Given this list of marker genes Mmp2, Ecm1, Atp1a1, Smarca1, Dusp16, Lpl, Arl4a, Mapk8, Runx1, Notch4, S100a6, Extl3, Htra1, Col7a1, Fabp3, Galnt3, Tns1, Cdkn2b, Tle3, Fzd6, Dnm2, Picalm, Cdc42ep5, Gfra1, Cald1, Tagln, Basp1, Foxp1, Jag1 (NCBI Gene Id 170642), Pcolce, Capg, Cyc1, Cnn3, Lipg, Krt18, Tgif1, G0s2, Ptpn14, Acaa2, Rad23a, Ccn1, Egr2, Net1, Galnt2, Ets2, Acta2, Gusb, Tsc22d1, Qki, Tjp2, Fabp5, Crim1, Plat, Ogfr, Ak2, Bpgm, Spin1, Sirpa, Chd4, Rpl27a, Srsf2, Hdlbp, Mfge8, Ceacam1, Egln1, Ehd1, Car8, Epas1, Cap1, Ier5, Cd14, Tgm2, Col16a1, Nfic, Hes1, Akt1, Crk, Clu, Sfpq, Wee1, Cyth1, Csnk2a1, Cpd, Ptk2b, Nrip1, Socs2, Acadvl, Clic1, Rab17, Fn1, Plod2, Fhl1, Fzd4, Cemip2, Vasn, Hspg2, Grb10, F3, Fmr1, St14, Ube2d1, Slc2a1, Lasp1, Tnc, Tgfbr1, Ccnk, Dpysl3, Bmp1, Marcksl1, Cyb561, Ets1, Has2, Sox9, Galc, Jpt1, Actg2, Ier3, Tpm2, Rps6ka3, Stat5b, Rab5c (NCBI Gene Id 19345), Dkk3, Mapk14, Il13ra1, Cdh11, Epb41l2, Pias3, Dlat, Comt, Ctla2a, Mmp14, Cotl1, Mal, Prkacb, F2r, Utrn (NCBI Gene Id 22288), Hk1, Tpsb2, Pdgfc (NCBI Gene Id 99691), Acat1, Timp2, Gsn, Sntb2 (NCBI Gene Id 20650), Kdr, Nfib, Cnn1, Diaph1, Itgav, Adam10, Cdkn1a, Ltf, Vcan, Cp, Tnfaip6, Tuba4a, Ptprk, Aplp2, Mef2c, Siah2, Foxa1, Cops2, Serpinb5, Cited1, Gja1, Tpp2 (tripeptidyl peptidase II), Col8a1, Wnt5a, Bhlhe40, Vegfa, here is a description of the gene set: Mouse Gene Set: MCBRYAN_PUBERTAL_TGFB1_TARGETS_UP Pubertal genes up-regulated by TGFB1. species: Mus musculus Expression microarray analysis identified over genes regulated during puberty in the mouse mammary gland. Most prominent were genes whose expression increased in parallel with pubertal development and remained high thereafter. Members of the Wnt, transforming growth factor-beta and oestrogen-signalling pathways were significantly overrepresented. Comparison to expression data from CITED1 knockout mice identified a subset of oestrogen-responsive genes displaying altered expression in the absence of CITED1. Included in this subset are stanniocalcin2 (Stc2) and amphiregulin (Areg). Chromatin immunoprecipitation revealed that ERalpha binds to oestrogen response elements in both the Stc2 and Areg genes in the mammary gland during puberty. Additionally, CITED1 and ERalpha localize to the same epithelial cells of the pubertal mammary gland, supporting a role for interaction of these two proteins during normal development. In a human breast cancer data set, expression of Stc2, Areg and CITED1 parallel that of ERalpha. Similar to ERalpha, CITED1 expression correlates with good outcome in breast cancer, implying that potential maintenance of the ERalpha-CITED1 co-regulated signalling pathway in breast tumours can indicate good prognosis. from publication McBryan J, Howlin J, Kenny PA, Shioda T, Martin F (PMID 17486082)